The following is a description of a gene set: Human Gene Set: GOMF_PHOSPHATIDYLSERINE_FLOPPASE_ACTIVITY studied in species Homo sapiens Catalysis of the movement of phosphatidylserine from the cytosolic to the exoplasmic leaflet of a membrane, using energy from the hydrolysis of ATP., and this is the list of marker genes: ABCA1, ATP8B3, ATP11A, ATP8A1, ATP8A2, ATP11B, ATP11C, ATP8B1, ABCA7